Given this list of marker genes PAFAH1B3, POLM, MARCHF6, TMEM183A, HADHA, RNF135, NUDT1, NXT1, CDK5, FAF1, HACL1, PHKA2, MIF4GD, PPT1, TMEM39B, OAT, RCL1, FBXL17, H2AJ, IFT20 (NCBI Gene Id 90410), PIGX, MAP3K6, MAP4K1, AMT, SNTB1, MBTPS1 (NCBI Gene Id 8720), STN1, PRR7, ASGR1, VAMP8, VCL, FAM204A, INPP5K, ZNF185, CSTL1, VSIG4, RPL23, MSRB2, CD37, LINC01003, SF3A1, MUSTN1, CLEC11A, CMTM2, H2AZ2, ARF5, SH2B3, S1PR3 (sphingosine-1-phosphate receptor 3), WBP11, CST5, MGMT, SLC25A29, BPI, SH3BP2, ANP32A, LINC02724, KLF7, CNNM2, ACAP1, HAGH, UBE2E3, GCHFR, GPD1L, APMAP, WDFY2, SYN2, ACYP2, STAT5B, JMY, MRPL40, ZNF362, DOCK5, TRAPPC1, NREP, RGS14, FBXO42, IFT52, STX16, DNMT3A, ANAPC13, PEBP1, SLC18B1, EIF2D, CAPNS1, ARL5A, NR4A1, XPO7, GAS5 (NCBI Gene Id 60674), ANKRD50, ABHD14B, MAP3K1, ARHGAP27, SNRPA, TM7SF3, ZG16B, ACBD6, SH3BGRL, TTC38, DCTN3, MBOAT1, LAS1L, CIDEB, FN3KRP, CDC40, WDR18, TAPBPL, KDM3A, GMPS, SRP14, PADI4, DCAF8, DIS3L, BACE1, TMEM219, MAPRE2, TMEM14C, TRAM2, APBB1IP, ZCCHC24 (zinc finger CCHC-type containing 24), KMT5A, LIN7A, PTPN18, POLE3, EIF3LP3, MPPE1, RSAD1, KBTBD11, R3HDM1, PTP4A1, RAB40C, PPIL3, SMIM27, SPATA6, NDRG3, SRM, LINC00528, NUDT18, FAM216A, ACOT8, RNF44, ZNRD2, NFATC2IP, VENTX, ARRB2, RAB3D, BCL2L11, PUSL1, PIP4K2A, CYSLTR1, CAMK2G, RHOT1, PYGL, APBB3 (NCBI Gene Id 10307), TKT, UROS, CHPT1, CCDC88C, GGTA1, SLC2A4RG, GRK3, MAPK3, KLF2, NUP93, FCGRT, CTDSPL, PCIF1, ZNF395, TLE3, ASGR2, LINC02209, HNRNPA1L2, ERP29, P2RY8, KCMF1, SOSTDC1, GPBAR1, SLC66A3, HMGB1, MLST8, F5, CYP2J2, CLEC3B, AP2M1, VEGFA (vascular endothelial growth factor A), HMGB2 (NCBI Gene Id 3148), PIK3R2, CAMK2D, EXOC4 (exocyst complex component 4), XPA, EIF2AK1, NAXE, PIGS, CRISPLD2, TMC8, SIDT2, NRIP1, CLEC4G, IDH3G, here is a description of the gene set: from publication Lund R, Aittokallio T, Nevalainen O, Lahesmaa R (PMID 14607935) species: Homo sapiens Th1 and Th2 cells arise from a common precursor cell in response to triggering through the TCR and cytokine receptors for IL-12 or IL-4. This leads to activation of complex signaling pathways, which are not known in detail. Disturbances in the balance between type 1 and type 2 responses can lead to certain immune-mediated diseases. Thus, it is important to understand how Th1 and Th2 cells are generated. To clarify the mechanisms as to how IL-12 and IL-4 induce Th1 and Th2 differentiation and how TGF-beta can inhibit this process, we have used oligonucleotide arrays to examine the early polarization of Th1 and Th2 cells in the presence and absence of TGF-beta after 0, 2, 6 and 48 hours of polarization. Human Gene Set: GSE2770_TGFB_AND_IL4_VS_IL12_TREATED_ACT_CD4_TCELL_48H_UP Genes up-regulated in CD4 T cells activated by anti-CD3 and anti-CD28: TGFB1 and IL4 (48h) versus IL-12 (48h).